Given this list of marker genes MEIS1, CDKN2C, KMT2A, EYA1, HOXA11, SIX4, MLLT1, FUT8, GRIA3, HPGD, HOXA10, HOXA9, SIX1 (SIX homeobox 1), here is a description of the gene set: Human Gene Set: KEGG_MEDICUS_VARIANT_MLL_ENL_FUSION_TO_TRANSCRIPTIONAL_ACTIVATION MLL-ENL fusion to transcriptional activation. Pathway ID: N00120. Pathway type: Variant. Pathway class: nt06240 Transcription. species: Homo sapiens Pathway Definition from KEGG: MLL-ENL => (MEIS1,HOXA9,HOXA10,HOXA11,SIX1,SIX4,EYA1,CDKN2C,HPGD,GRIA3,FUT8)